The following is a description of a gene set: Recurrent Haemophilus influenzae infections studied in species Homo sapiens Increased susceptibility to Haemophilus influenzae infections as manifested by recurrent episodes of infection by Haemophilus influenzae. Human Gene Set: HP_RECURRENT_HAEMOPHILUS_INFLUENZAE_INFECTIONS, and this is the list of marker genes: TGFB1, CLCA4, SCNN1B (NCBI Gene Id 6338), GCLC, SLC11A1, KCNN4, SLC6A14, SCNN1G, MIF, DCTN4, CFI, CEACAM6, RPGR, SLC26A9, HFE, SCNN1A, STX1A, CEACAM3, SERPINA1 (serpin family A member 1), CFTR, GSTM3, SLC9A3, HMOX1, EDNRA, IL2RG